Given this list of marker genes Phkg1, Zfand5, Ints2, Dbp, Fut9, Prkaa2, Dlx2, Herpud2, Nrk, Unc79, Slc38a2, Plxna1, Ipo9, Tnrc18, Ube2a, U2surp, Elavl1, Ankrd44, Agpat5, Map4k3, Hapstr1, Csrnp3, Pid1, Pcnx1, Stag2, Dcaf10, Glrb, Ahcyl1, Tmppe, Vasp, Fbxl17, Tbpl2, Shprh, Dtwd2, Stox2, Cpne3, Guf1, Cnr1, Sumf2, Ino80d, Nufip2, Sdcbp, Pptc7, Tlk2, Slc22a23, Trhr, Tmem185b, Naaladl2, BC016579, Dph3, Pax3, Pax9, Slit3, Tial1, Ndst3, Tsc22d3, Ppip5k2, Ptpro, Bcl11a, Asxl2, Tnfsf10, Cpsf6, Hecw2 (NCBI Gene Id 329152), Rbms3, Abtb3, Rbm24, Sfmbt1, Nab1, Ttbk2, Jak1, Tmem65, Ppargc1a, Clec4d, Phf6, Ppp1r3a, Bloc1s6, Zfp800, Calu, Zfp24, Clp1, Zbtb41, Yipf4, Limk1, Map3k5, Cul4b, Socs4, Ipo5, Nxpe3, Mtx3, Itpripl1, Adrb2, Dph7, Utp18 (NCBI Gene Id 76152), Rag1, Nlk, Gabrb2 (NCBI Gene Id 78533), Uck2, Foxd3, Hnrnph1, Msi2, Prkab2, Cep135, Bbx, Gucy1a2, Larp4, Senp7, Iqgap2 (IQ motif containing GTPase activating protein 2), H2-T24, Ebf1, Runx2, Qki, Eri1, Bcl2, Smchd1, Atxn7l2, Dclk1, Pcna, Cdk6, Atp6v1c2, Scai, Rb1cc1, Sppl2a, Cxadr, Arrdc3, Dner, Stimate, Dmtf1l, Lmnb1, Camk4, Gpr3, Acap2, Mdfic, Nfib, Palld, Zfp174, Zfp36l1, Wnk1, Ttc39b, Slc12a2, Cavin2, Tlcd4, Wdr1, Csnk1g3, Pafah1b1, Pkn2, Clock, Actb, Osbpl8, Col27a1 (collagen, type XXVII, alpha 1), Rad21, Pus7, Lrrc4c, Bltp3b, Abcd2, Mef2a, Gtf3c4, Xrn1, Pgap1, Cbln2, Rngtt, F2r, Sox9, Dennd5b, Tet1, Tob2, Trim71, Wscd2, Dusp10, Piezo2, Smad2, Med14, Glt8d1, Khdrbs1, Cdc40, Dip2b (disco interacting protein 2 homolog B), Rbpms, Tbc1d15, Acsm3, Lyzl1, Pnoc, Rhoa, Vps13b, Ints10, Chmp1b2, Ak1, Lix1, Zfp148, Wdr33, Tmod3 (NCBI Gene Id 50875), Ralyl, Dag1, Plxnd1, Irs1, Stxbp5 (syntaxin binding protein 5 (tomosyn)), Hmcn1, Slc2a3, Irf2, Dtl, Lyar, Dmxl1, Ybx1, Tmem154, Icos, Eif5a2, Prepl, Slc2a13, Bclaf1, Tnpo1, Nipa2, Btg2, Acot10, Wsb1, Strbp, Mob1b (MOB kinase activator 1B), Pcdhb9, Nucks1, Nrf1, Fat3, Mybl1, Ggcx, Rap2c, Chp1, Ranbp3l, Pggt1b, Lrrtm2, Ap1s2, Tmem39a, Ccdc71l, Nus1, Alkal2, Gclm, Negr1, Ppm1k, Psmd12, Cntnap2, Nudt7 (nudix hydrolase 7), Pdcd10, Dnajb9, Mttp, Atxn1, Spint2, Cdc14b, Ptp4a1, Mmd, Runx1, Rc3h1, Hus1, App, Zfp503, Fam171b, Tut4, Nradd, Enah, Bmpr2, Trim33, Stx16, Atp11a (NCBI Gene Id 75344), Itk, Dock1, Adamts3, Ssbp2, Gem, Nsd2 (nuclear receptor binding SET domain protein 2), Mapk6, Ube3a, Zfp518b, Zmpste24, Mex3b, Naa40, Ttc13, Sel1l, Zfp354c, Psma2, Zfp362, Evi2a, Tmem170b, Ago3, Tbc1d9, Sec23ip, Ust, Kmt5b, Luc7l3, Fgd4, Apol7e, Zfp11, Nlgn3, Rnft1, Lhx5 (LIM homeobox protein 5), Angptl7, Nampt, Spry1, Msantd3, Ssbp1, Tgfbr1 (transforming growth factor, beta receptor I), Itpr1, Fmr1, Atp6v1a, Srsf1, Neto2, Acly, Chst11, Rspry1, Pi15, Itsn2, Pign, Lrrc55, Trappc10, Ttc14, Hycc1, Ackr3, Lair1, Arl14ep, Meis2, Lat2, Map4k4, S100a10, Hsph1, Efnb2, Dcaf8l, Lin54, Ptprs, Ptbp3, Prkx (NCBI Gene Id 19108), Kdm7a, Cirbp, Rgs9bp, Pcdh10, Mex3d, Zfp236, Sgip1, Ppp2cb (protein phosphatase 2 (formerly 2A), catalytic subunit, beta isoform), Nphp4, Ing3, Cxcl16, Grm7, Nova1, Depdc7, Galnt7, Pex13, Ube2w, Cd72, Srsf3, Fam76b, Plcb1, Pak3, Junb, Abraxas1, Pcf11, Cask, Sh3rf1, Sp3, Stambp, Rbpj, Rif1, Ap1s3, Ube2g2, Sos1, Leprotl1, Strn3, Snx10, Atf2, Steap2, Epha7, Canx, Hnrnpr, Ssh2, Phf13, Pde7a, Pias2, Stc1, Cpeb1, Arhgap32, Ttc32, Scn1a, Ncbp3, Tpx2, Papolg, Slc35f1, Smim3, Selenot, Grhl2, Epb41, Npr3, Miga1, Tfap4, Zfp609, Zkscan8, 4933428G20Rik, Homer1 (NCBI Gene Id 26556), Hhex, Jmy, Heatr3, Rora, Zik1, Taf3, Commd8, Eif4ebp2, Panx3, Sgk3, Ism1, Spry2, Bbs5, Mgat4a, Ppig, Palb2, Ppm1b, Sap18, Tgfbrap1, Egf, Slc38a10, Fbxo5, Ror1, Ccdc6, Braf, Ppp1r9a, Styk1, Ugdh, Trpc6, Fchsd2, Rmnd5a, Rfx7, Atl2, Dusp3, Nxf1, Mllt11, Hnrnpk, Taf2, Gas2l3, Ppp4r3b, Cav2, Tead1, Megf10, Irf2bp2, Lamp2 (NCBI Gene Id 16784), Lamp3, Fam204a (NCBI Gene Id 76539), Mapk8, Nexmif, Lin9, Nkx2-1, Ccdc85b, Pcnp, Ube2j2, Prpf38b, Adarb2, Pde1a, Slc15a1, Spin4, Tasp1, Tet3, Sf1, Morc4, Hoxa3, Nxt2, Csmd3, Srcap, Gabra1, Apbb2, Sema5a, Slc6a6, Hnrnpa2b1, Trim30d (NCBI Gene Id 209387), Map3k2, Arl2bp, Nudt17, Twist1, Kat6a, Abhd17b, Hmgn1, Skint10, Cdh23, St8sia4, Acp3, Pcdhb16, Dusp22, Mcl1, Raph1, Fhip2a, Erbin, Hif1a, Rbm3, Cdk13, Slc24a2, Lpgat1, Tmem239, Klhl12, Gpkow, Ifngr1, Zfand6, Saxo2, Anpep, Acsl4, Smurf2, Lgr5, Zfp369, Inpp4b, Plxna2, Gm7616, Mapk4, Zfp354a (NCBI Gene Id 21408), Piwil1, Rnmt, Mrpl10, Coro2a, Tent5d, Cd24a, Cbx6, Adm, Jrkl, Arfgef3, Apol7b, Creb1, Adamts6, Sgcb, Dck, Phtf2, Cdc73, Lrrc39, Pja2, Trps1, Cyrib, Ikzf2, Poglut2, Cggbp1 (CGG triplet repeat binding protein 1), D16Ertd472e, Dach1, Rbm47, Tspyl4, Dnajc3, Cdv3, Nemp1, Rbm12b2, Naa30, Kif5b, Blcap, Grm5, Gtf2h1, Bcl2l11, Asf1a, Pdxk, Rfx3, Cnot11, T2, Zbtb44, Rbm41, Zic2, Wdr73, Rab12, Zdhhc15, Ctdspl2, Galnt1, Uty, AI597479, Tmed7, Agps, Dgat2, Ptprf, Pgm2l1, Smg1, Zfp235, Cxxc4, Ttc9c, Hoxc4, Phc3, Tmx3, Acsl3, Purb, Zbtb37, Tmod2, Slitrk2, Kcns2, Znrf3, Rc3h2, Cnot6, Lca5 (NCBI Gene Id 75782), Pnpla8, Ogfrl1, Ranbp9, Nr2f2, Rer1, Dgkk, Map3k7, Prkg1, Dcdc2a, Rnf41, Stil, Ewsr1, Col4a4, Exoc5, R3hdm1, Pcmtd1, Etv6, Tlk1, Tcf12, Pld5 (NCBI Gene Id 319455), Ptprm, Gsdmc4, Slc24a3, E2f3, Ppp3ca, Diaph1, Ghsr, Fam222b, Vsig10, Pgr, Cdc14a, N4bp2l1, Txnrd1, Gfra1, Dnm1l, Zfhx3, Ap3m2, Zfp354b, Slc40a1, Ppil4, Prkca, Gria2, Cul4a, Ggps1, here is a description of the gene set: Mouse Gene Set: MIR_290B_5P Genes predicted to be targets of miRBase v22 microRNA mmu_miR_290b_5p in miRDB v6.0 with MirTarget v4 prediction scores > 80 (high confidence targets). species: Mus musculus from publication Chen Y, Wang X (PMID 31504780)